The following is a description of a gene set: species: Homo sapiens Human Gene Set: REACTOME_RAS_ACTIVATION_UPON_CA2_INFLUX_THROUGH_NMDA_RECEPTOR Ras activation upon Ca2+ influx through NMDA receptor, and this is the list of marker genes: DLG4, CAMK2D, ACTN2, NRAS, GRIN2D, DLG3, KRAS, DLG2, RASGRF2, DLG1, HRAS, CAMK2B, RASGRF1, GRIN2B, GRIN1, CAMK2G, CALM1, NEFL, LRRC7, CAMK2A